The following is a description of a gene set: from publication Chen Y, Wang X (PMID 31504780) Mouse Gene Set: MIR_6337 species: Mus musculus Genes predicted to be targets of miRBase v22 microRNA mmu_miR_6337 in miRDB v6.0 with MirTarget v4 prediction scores > 80 (high confidence targets)., and this is the list of marker genes: Rcsd1, Tead1, Brinp2 (bone morphogenic protein/retinoic acid inducible neural-specific 2), Med31, Bmper, Map3k8, Tex264, Oas3, Rad54l2, Dlx3, Wnk1 (NCBI Gene Id 406236), Nlgn2, Gxylt2, Nfatc2, Pcp4l1, Asb6, Zdhhc8, Pdcd1lg2, Tshz3, Cnr1, Nhs, Tyms, Calr (NCBI Gene Id 12317), Nsmce2 (NCBI Gene Id 68501), Ttll6, Col4a2, Chrm4, Prr29, Cbx5, Gadl1, Chmp1b, Pkp1, Rc3h2, Gimap3, Ndrg2, Dclk1, Pklr, Zfp429, Efnb3 (NCBI Gene Id 13643), Tnfsf18, Foxk1, Wdr82, Pla2g4e, Sirt1, Ppme1, Usp30, Slc30a4, Pik3r1, Hic2, Fosb, Abhd10, Krtap13, Ttc17, Rara, Cyb5d2